Given this list of marker genes Wnk1, Cnot6, Mapk8, Spire1, Iqgap2, Sgcb, Pdgfra, Acbd5, Kcnj2, Daam1, Dpysl2, Gga3, Tbc1d8, E2f2, Jarid2, Fmr1, Tnrc6c, Map3k12, Wnt2b, Smoc1, Cmpk1, Arhgap21, Hoxb1, Tshz1, Heg1, Socs6, Lrrtm2, Map3k8, Lcorl, Blcap, Mdn1, Cnot7, Rap2c, Mmgt1, Ddx6, Esr1, Neurog1, Adamts20, Pmepa1, Tmem250, Tbl1xr1, Snapin, Snx5, St8sia5, Thsd7a, St18, Il25, Zfp655, Plekhg5, Ccdc126, Garem1, Ago4, Reps2, Arhgap1, Mphosph9, Dcbld2, Robo2, Hs3st5, Kdm2a, Sulf1, Stx6, Erbin, Klhl20, Arap2, Smoc2, Acsl4, Phf3, Gja1, Clip1, Zmat3 (NCBI Gene Id 22401), Acer2, Med12l, Laptm4a, Stxbp5, Rab5a, Mat2b, Btbd3, Dgke, Cdk19, R3hdm1, Mecp2, Sybu, Gpr137c, Prr14l, Btaf1 (B-TFIID TATA-box binding protein associated factor 1), Ankib1, Enpp5, Rnf216, Fastk, Sbno1 (NCBI Gene Id 272223), Zcchc14, Ptp4a1, Dennd10 (DENN domain containing 10), Med15, Sh3d19, Rfx7 (regulatory factor X, 7), Stimate, Tsc1, Pak6, Hprt1, Ereg, Atp2b2, Pparg, Zfp113, Btf3l4, Phaf1, Appl1 (NCBI Gene Id 97938), Ston2, Emx2, Zfp11, Psap, Epc2, Mapk1, Cast, Usp32, Rasd1, St6galnac3, Wee1, Pgm2l1, Asxl2, Ar, G3bp2, Acvr1, Snip1, Nacc2, Pcnx1, Maf (MAF bZIP transcription factor), Ago1, Casd1, Kmt2c, Mb21d2, Sel1l3, Vps37a, Tgfbr1 (NCBI Gene Id 674605), Tbcel, Ppp6r1, Prkd3, Kcna4, Skida1, Psd, Acsl1, Caprin2, Nectin3, Eda (NCBI Gene Id 13607), Larp4, Togaram1, Csmd1, Kbtbd8, Ldlrad4 (low density lipoprotein receptor class A domain containing 4), Tes, Dnajc24, Phf12, Plcb1, Sphk2, Cbfb, Mfsd6, Cd69, Memo1, Fibin, Tbc1d12, Lrp4, Rtn1, Dsel, Fcho2, Akirin2, Chst1, Mybl1, Gpatch8, Wdfy3 (NCBI Gene Id 72145), Itpr1, Eogt, Cep170, Adcy1, Slmap, Nckap5, Pou4f1, Mbnl1, Ccny, Mid1ip1, Cpeb1, Spart, Fam234a, Gon4l, Sowahb, Lrig1, Nsd3, Akap11, Pogz, Ube2d2a, Ldaf1, Mllt6, Fut9, Zbtb18, Zbtb4, Rnf38, Npepl1, Elk3, Spred1, Ubl3, Smad5, Gng12, Npnt, Pxk, Mex3d, Dennd1a, Prkaa1, Psd3, Mon2, Calm2, Nol4, Cds1, Smarcd2, Btbd7, Arhgap12, Btg1, Relch, Abcc5, Vps29, Tet3, Mctp1, Tnf, Zfp609, Ptprg, Socs5, Bnip2, Brwd1, Atxn1, Mdfic, Impdh1, Naa30, Fermt2, Dll1, Abhd3, Mdm4, Jade1, Miga2, Stim2, Lrp8, Lonrf3, Lgalsl, Cyld, Snx2, Lonrf1, Clcn5, Cltc, Tspyl2, Atg16l1, Pik3cb, Jmy, Ulk2, Tapt1 (NCBI Gene Id 231225), Cfl2, Usp8, Csnk1g1, here is a description of the gene set: species: Mus musculus Mouse Gene Set: MIR_301A_3P_MIR_301B_3P from publication Chen Y, Wang X (PMID 31504780) Genes predicted to be targets of miRBase v22 microRNA mmu_miR_301a_3p, mmu_miR_301b_3p in miRDB v6.0 with MirTarget v4 prediction scores > 80 (high confidence targets).